Given this list of marker genes Serpind1, Acrbp, Spint1, Gbp2, Serpinb3a, Klk4, Naaladl1, Uchl4, Shh, Usp35, Adamts9, Ggt1 (NCBI Gene Id 14598), Pttg1, Scrn3, Lta4h (leukotriene A4 hydrolase), Itih3, Cela3b, Serpinb3d, Tpp2, Usp49, Usp37, Pappa2, Gzmd, Ubac2, Dpp4, Josd1, Psen1, Usp2, Adam23, Atxn3, Casp12, Folh1, Tmprss11f, Cfap44, Gzmg, Adam1b, Rhbdd2, Ecel1, Tifab, Wfikkn2, Usp7, Prrg4, Cirop, Ace, Spock1, Spink13, Parl, Dnpep, Klk13, Stfa2l1, Klk6, Wfdc9, Pbp2 (phosphatidylethanolamine binding protein 2), Usp44, Rhbdl3, Mme, Rnpep, Ctsh, Mcpt1, Yod1, Csn2, Pik3ip1, Adrm1b, Adamts3, Wfikkn1, Tmprss7, Prss46, Usp28, Serpina1a, Dpp10, Agbl3, Ufsp1, Stfa1, Pmpca, Nrdc, Ctsll3, Itih4, Nlrc4, Otud6b (NCBI Gene Id 72201), Clca1, Cps1, Serpina3b, Senp6, Mmel1, Tmprss4, Usp1, Birc6, Cpb1, Htra3, Tank, Sprtn, Cstdc3, Pcsk9, Adam32, Cfi, Uchl1, Prss30, Serpinb12, Ctsl, C1s2, Timp3, Uchl5, Serpina3a, Casp2, Ufsp2, Usp11, Lonp1 (lon peptidase 1, mitochondrial), Psme1, Cops6, Prss3b, Klk1, Cst5, Rps27l, Usp24, Otud4, Corin, Mmp19, Cav1, Serpina10 (NCBI Gene Id 217847), Tinagl1, Xpnpep2, Crim1, Cstdc5, Dpp9, Ihh, Usp20, Spink6, Mmp15, Gm4787, Fam111a, Usp32, Serpina3m, Psmd14, Plg, Ctss, Pgpep1, Thop1, Usp25, Slpi, Otub1, Adamts12, Papln, Tpsb2, Tysnd1, Alg13, Mmp8, Bace1 (NCBI Gene Id 97509), Itih1, Stambp, Sfrp2, Ace3, Ermp1, Dpep1, Gm7298 (predicted gene 7298), Casp14, Smr2, Hgfac, Casp1, Adamts4, Ngf, Sva, Hpn, Wfdc8, Ctsa, Klk12 (NCBI Gene Id 69511), Adam19, Adamts18, Serpina9, Prnp, Nlrp2, Stfa2 (NCBI Gene Id 20862), Smr3a (NCBI Gene Id 20601), Ctsz, Ctla2b, Serpina3k, Klk1b1, Adamts6, Mmp25, Spint3, Wdr20rt, Itih5, Pzp, Usp46, Casp7, Tnfrsf10b, Prss59, Clca3a1, Cstl1, Atg4c, Serpinb7, Zup1, Usp13, Ide, Cst3, Tmprss11d (NCBI Gene Id 231382), Serpinb8, Mmp23, Cpa4, Serpina6, Otud1, Sfrp1, Prss1, Semp2l2b, Tmprss5, Ybey, Htra4, Ctsj, F7, Dpep2, Prtn3, Oma1, Cpxm2, Adamts14, Adamts13, Kng2, Mmp20, Naalad2, Snca, Endou, Sec11a, Serpinb9g, Cpne1, F3, Mbtps2, Spink11, Eif3f, Mmp10, Spink12, Tasp1, Aph1b, Stfa3, Usp38, Bmp1, Casp9, Csta3, Klk1b9, Usp34, Tll1, Cflar, Adam26b, Serpinb3c, Psmb8, Prss28, Cst13, Col7a1, Mcpt2, Klk9, Adam17, Aim2, Serpina1d, Klk1b22, Pappa, Ctrl, Acr, Htra2, Cast, Serpinb6c, Mmp21, Mmp14, Gapdh-ps15, Klk8, Senp3, Senp2, Spink1, Casp6, Cstdc6, Lmln, Cpn1 (carboxypeptidase N, polypeptide 1), Mmp3, Adam24, Pmpcb, Gzmc, App, St14, Otulinl, Tmprss11c, Tmprss15, Mmp1b, Mpnd, Lxn (latexin), Sval1, Anxa2, Nln, Prss16, Serpinf2, Usp26 (ubiquitin specific peptidase 26), Klk7, Pcsk1n, Psmb7, Serpinb3b, Serpinb6a, Serpini1, Usp21, Klk14, Usp8, Klk1b5, Mug1, Fn1, Prss29, Csta2, Vcpip1, Usp22, Cma1, Usp45, Desi1, Psenen, Pcsk7, C2, Adam10, Ggt6, Clca4a, Serpinb10, Apaf1, Agbl5, Prss33, Asprv1, Cpa1, Cts7, Gzma, Prss45, Psme2, Prss58, Sorl1, Plat, Usp39, Cts3, Adam18, Adam29, Serpina3f, Uchl3, Apeh, Prss35, Prcp, Lvrn (laeverin), Tmprss11b, R3hdml, Fap, Adam22, Aga, F9, Prss23, Capn15, Spink8, Pi16, Agtpbp1, Pebp1, Prss1l, Ambp, Prss40, Mmp1a, Smr2l, Wfdc15a, Birc5, Zmpste24 (NCBI Gene Id 230709), Timp4, Gzmk, Pepd, Dhh, Bst2, Adam20, Try10, Col6a3, Serpinb6b, Matcap2, Wfdc17, Aplp2, Tmprss12, Cym, Rhbdl2, Cndp1, Klk10, Klk1b24 (NCBI Gene Id 16617), Ctsd, Wfdc2, Mapk9, Cd109, Capn7, Ddi2, Adam7, Ctsm, Myrf, Nlrp3, Csta1, Tmprss11e (NCBI Gene Id 243084), Vsir, Xpnpep1, Proz, 4930486L24Rik, Hc, Ctsc, Immp1l, Psmb3, Prepl, Otub2, Josd2, Usp16, Ddi1, Cpd, Mmp12 (matrix metallopeptidase 12), Lgmn, Atp23, Usp15, Prss27, Mmp24, Aebp1, Serpinb1a, Ggt7, Gzmf, C1rl, Mindy2, Pigk, Spink10, Usp18, Adamts2, Hp, Serpinb6d, Usp51, Mbtps1, Prss56, Otud7b, Pm20d1, Prep, Arrb1, Sppl2a, Serpina1c, Ece1, Pidd1, Prss55, Adam15, Usp48, Serpinb9e (serine (or cysteine) peptidase inhibitor, clade B, member 9e), Wfdc1 (NCBI Gene Id 67866), Adam1a, Sec11c, Adamts19, Tmprss13, BC051665, Usp17lc, Ndel1, Bad, Cts6, Gzme, Rhbdl1, Cops5, Cela1, Gpc3, Nup98, Lap3 (NCBI Gene Id 66988), Mindy4b-ps, Tll2, Capns2 (calpain, small subunit 2), Klk15, Usp17le, Cstdc1, Adamts17, Mmp17, Adam30, Wfdc12, Usp43, Mmp11, Usp33, Aopep, Try4, Adam2, Atg4a, Serpina3n, Sval3, Wfdc16, Otud5, Capn6, Spink7 (serine peptidase inhibitor, Kazal type 7 (putative)), Usp36, Usp29, Capn8, Capn2, Lnpep, F10, Asrgl1, Eef1ece2, Tgfb1, Klk1b21, Klk1b8, Pgc, Capn12, Actmap, Metap1, Cpa5, Rbp3, Agbl4 (NCBI Gene Id 78933), Pitrm1 (pitrilysin metallepetidase 1), Adam12, Usp9x, Gapdhrt2, Ctso, Scrn2, Ahsg, Mindy3, Espl1, Adam34l, Rce1, Serpinb9f, Adrm1, Cpm, Adam28, Npepps, Thbs1, Vash2 (NCBI Gene Id 226841), Klk1b16, Agbl2, Htra1, Serpinb13, Pm20d2, Atg4d, Metap2, Usp17ld, Senp7 (NCBI Gene Id 77714), Vash1 (NCBI Gene Id 263410), Phex, Renbp, Blmh, Prss41, Vcp, Klk1b11 (NCBI Gene Id 16613), Adam6a, Mysm1, Sppl3, Tmem59, Dpp6, Usp27x, Col28a1, Wfdc6a, Rhbdd3, Serpinb9c, Wfdc6b, Cd46, Aph1c, Ctsw, Desi2, Pcsk6, Amz1, Pi15, Cst7, Adamts20, Yme1l1, Gapdh, Prss32, Cst8, Wdr20, Cpz, 1810009J06Rik, Pcsk4, Dmwd, Xpnpep3 (NCBI Gene Id 321003), F11, Hspd1, Serpinb11, Uqcrc2, Serping1, Serpina12, Xiap, Spink4, Psmd7, C1s1, Bap1, Prss3, Semp2l2a, Afg3l1, Tgm2, Usp54, A2ml1, Tmprss6, Usp5, Rhbdf2 (rhomboid 5 homolog 2), Rock2, Ky, Habp2, Nlrp1b, Hgf, Klk5, Tmprss11g, Usp10 (ubiquitin specific peptidase 10), Capns1, Ctse, Adam9, Ovch2, Rack1, Npepl1, Spink5, Gbp2b, Ctrc, Psmb9, Casp4, Capn5, Capn9, Prss48, Prss38, Gbp5, Usp40 (ubiquitin specific peptidase 40), Usp9y, Adamts10 (NCBI Gene Id 224698), Klkb1, Svbp (small vasohibin binding protein), Casp8ap2, Tfpi, Adam25, Serpinb9, Tpsg1, Serpina11, Dpp3, Cela3a, Zc3h12a, Usp50, Tnfaip3, Prpf8, Amz2, Astl, Sppl2c, Prss50, Ctsf, Serpinf1, Clpp, Dpp7, Afg3l2, Adam8, Hint1, Cma2, Sval2 (seminal vesicle antigen-like 2), Tmprss11a, Trhde, Prss21, Scrn1, Serpina3c, Ren1, Usp17lb, Elane, F2, Usp14, Kel, Pdia3, Serpinb6e, Nudt16, Reln (reelin), Ace2, Brcc3dc, Spink2, Pcolce, Prrg2, Serpine3, Prss12, Prrg3, Ctsb, Mmp13, Gm2663, Birc7, Serpine1, Umodl1, Sppl2b, A2m, Usp53, Ctsg, Gzmm, Prrg1, Wfdc3, Cntnap5a (contactin associated protein-like 5A), Usp30, Clpx, Adamts1, Psme4, Tmprss9, Lactb, Timp1, Prss52, Try5, Rhbdf1, Adamts7, C1rb, Brcc3, Psmb5, Ece2, Tfpi2, Prss2, C3, C1ra (NCBI Gene Id 50909), Scpep1, Psmb11, C4b, Klk11, Wfdc11, Adam11, Serpinb1b, Pga5, Serpina3i, Prss43, Serpina1f, Mindy4 (MINDY lysine 48 deubiquitinase 4), Spg7, Cep63, Ctsq, Mep1b (NCBI Gene Id 17288), Adam6b, Serpinb2, Cpxm1, Mep1a, Adgb, Cfb, Kdm8, Wfdc15b, Usp19, Cpa6 (NCBI Gene Id 329093), Klk1b27, Ggh, Metap1d, Cst12, Mcpt9, Senp8, Pcolce2, Psen2, Mmp16, Gpaa1, Adam34, Jmjd7, Ctsr, Ngp, Capn10, Nkx3-1, Serpinb9d, Otud7a, Prss42, Prss39, Pcsk1, Adam39, Prss36, Klk1b26, Rnpepl1, Serpini2, Adam4, Spock3, Plau, Cpe, Pip, Adamdec1, Napsa (napsin A aspartic peptidase), Klk1b4, Erap1, Fbln1, Anpep (alanyl aminopeptidase, membrane), Serpina5, Usp3, Mmp2 (NCBI Gene Id 17390), Gapdhrt, Serpina1e, Serpinc1, Timm50, Mindy1, Pcsk2, Unc5cl, Cpa2, Cfd, Cst9, Enpep, Prss3l, Immp2l (NCBI Gene Id 93757), Masp2, Cpvl, Pycard, H13 (histocompatibility 13), Dpp8, Mcpt4, Nlrp1a, Prss22, Prss8, Mug2, Casp3, Malt1, Eif3h, Serpinb5, Ncstn, Prss37, Prss51, Rarres1, Otud3, Usp31, Adamts15 (ADAM metallopeptidase with thrombospondin type 1 motif 15), Otulin, Capn3, Agbl1, Rhbdd1, Serpina3j, Prss44, Fetub, F12, Adam3, Reck, Senp1, Pgpep1l, Usp17la, Simc1, Stambpl1, Masp1, Lonp2, Adamts8, Wfdc5, Bace2, Cpa3, Capn1, Adam33, Kng1, Serpinh1, Psme3, Casp8, Wap, Tpsab1 (tryptase alpha/beta 1), Proc, Cela2a, Atp2a3, Ggt5, Capn11, Serpinb9b, Otud6a, Prss34, Naip1, Cts8, Agt, Serpinb9h, Uspl1, Prss54, Hmces, Usp4, Nrip2, Usp42, Semp2l1, Serpina3g, Gzmb, Cst11, Cpb2, Dpep3, Adam21, Wfdc10, Senp5, Tpp1 (NCBI Gene Id 12751), Timp2, Eppin, Mmp9, Prss57, Psmb6, Spint4, Itih2, Ltf, Wfdc13, Crb2, Usp12, Cstdc4, Hrg, Prss53, Bcl10, Adamtsl2, Adamts5, Tmprss3, Ctsk, Zranb1, Mipep, Serpine2, Cstb, Serpina7, Matcap1, Adamts16, Trabd2b, Cpq, Cyld, Park7, Abca2 (NCBI Gene Id 98943), Furin, Nrip3, Serpina16, Wdr48, Wfdc18, Mcpt8, Aph1a, Ctrb1, Psmb10, Clca2, Psmd13, Spint2, Bin1, Adam5, Mmp7, Mmp27, Mansc4, Serpina1b, Gzmn, Atg4b, Cndp2, Pcsk5, Mst1, Wfdc21, Elp2 (elongator acetyltransferase complex subunit 2), Tmprss2, Adam26a, Usp47, Atg4a-ps, Capn13, Psmf1, Klk1b3, Serpinb1c, Mmp28, here is a description of the gene set: Mouse Gene Set: GOMF_PEPTIDASE_ACTIVITY Catalysis of the hydrolysis of a peptide bond. A peptide bond is a covalent bond formed when the carbon atom from the carboxyl group of one amino acid shares electrons with the nitrogen atom from the amino group of a second amino acid. studied in species Mus musculus